Given this list of marker genes PPFIA4, PADI4, NDRG1, IRF2BP2 (NCBI Gene Id 359948), RCSD1, CARD19, LY86, GPR183, IQSEC2, UNC93B1, MIGA2, BATF3, SRSF9 (NCBI Gene Id 8683), RNASE4, ZCCHC24, VPS26A, SLC39A1, HPSE, SLPI, EIF2AK3, RBKS, PGD, FGL2, PLCL2, SLFN12L, AK8, SERP1, LGALS9B, B3GNT8, KHK, CTDSPL, RANBP10, ABCA9 (ATP binding cassette subfamily A member 9), ANXA9 (annexin A9), ESR1, SERPINB8, ZBED3, HPS3, CD40, MRPL28, SLC25A6, CLEC4A, NFIC, RSAD2, CLCA4, ARHGEF37, EPSTI1, IFIH1, COX6B2, ALOX5AP (NCBI Gene Id 241), RPSA, ATRNL1 (attractin like 1), IFT74, LGALS1, PSTPIP1, AP2A2, IDH2, ARHGAP15, IAH1, PABPC1, KDM2B, LAMTOR4, EMB, ADAR, PAPSS1, OGFR, SLC31A2, MKI67, STOM, DNA2, TIMELESS, FOXRED2, MRPL58, SEC61B, NAA10, RTP4, QPCT, GPI, DPYSL2, SULF2, PPIB, PABPC1L, B3GLCT, TAGLN2, GAB1, RAB31, ARFIP1, NOP53, MCUB, H2AJ, CD84, CRIP1, AHR, PPP1R21, MPP1 (NCBI Gene Id 4354), PIP4P1, CSTB, CCR2, RPL28, CD52, SDHD, AGRN, PLEC, P2RY6, TBXAS1, NIBAN2, SMOX, RPL7A, SMIM5, GLIPR1, NFIA, PLXND1, COX8A, HOPX, LXN, MPC1, EVI2B, NDUFA1, CD93, POLR1D, TBC1D2, VIM, OSBPL11, MSR1, HACD4, FAM89B, SMN1, SSBP2, APP, CEBPD, NLRP3, CITED2, RNF217, TUSC1, VDAC2, RTN4, HLA-DMA, F13A1, ANXA1, DYRK2, MAN2A2, DHX40, ANKLE2, ADAM19, RASSF4, GSN, CMTM7, TMEM71, BSCL2, RGS10, STING1, TNFRSF21, LGALS3, RPL24, CCDC102A, LDHB, HVCN1, RABGAP1L, GBP4, TIAM1, NDUFS8, MARCHF5, KDM7A, MX2, SOCS6, EIF3E, MLKL, S100A6, ICAM1, PRDX5, TDRD7, ADISSP, ACVRL1, APRT, MZT2B, PSME4, CIBAR1, STARD8, AKR1A1, EVA1B, SUB1, TGFBI, FAM111A, INPP5K, NCF1, CEBPA, SLC7A8, ANXA5, RPL36A, ATP2B1, IFITM3, VCL, IFI35, HADH, ANXA3, PLAC8, DYRK3, RACGAP1, SLC30A1, RPS9, here is a description of the gene set: studied in species Homo sapiens from publication Muranski P, Borman ZA, Kerkar SP, Klebanoff CA, Ji Y, Sanchez-Perez L, Sukumar M, Reger RN, Yu Z, Kern SJ, Roychoudhuri R, Ferreyra GA, Shen W, Durum SK, Feigenbaum L, Palmer DC, Antony PA, Chan CC, Laurence A, Danner RL, Gattinoni L, Restifo NP (PMID 22177921) Serial comparison between Th1 and Th17 tumor-specific cells cultured in vitro and ex vivo after transferred into sublethaly irradiated B6.PL mice. Th17-derived cells acquire Th1-like properties in vivo but maintain a distinct molecular profile. Human Gene Set: GSE26030_TH1_VS_TH17_DAY15_POST_POLARIZATION_DN Genes down-regulated in T helper cells 15 days post polarization: Th1 versus Th17.